Given this list of marker genes AR, GC (GC vitamin D binding protein), TTR, RBP1, CRABP2, GNMT, RXRA, RXRG, PCCA, ESR2, SCP2, NR3C2, HSD17B4, OSBP, RLBP1, SERPINA6, FOLR2, CRABP1, SHBG, ACACB, ACACA, ALDH1A1, SCGB1A1, HNF4G, SCGB2A1, SULT1E1, here is a description of the gene set: Steroid hormone receptors and binding proteins. species: Homo sapiens Human Gene Set: MODULE_404